Given this list of marker genes CHRNG, HSPG2 (heparan sulfate proteoglycan 2), SOX9, CHST14, CHRNA1, CHRND, RIPPLY2, DSE, FLNB, ARSL, SLC26A2, GZF1, here is a description of the gene set: Human Gene Set: HP_ABNORMAL_CERVICAL_CURVATURE studied in species Homo sapiens The presence of an abnormal curvature of the cervical vertebral column. Abnormal cervical curvature